Given this list of marker genes GMPPB, DIS3L2, PPP1R12A, TTC7A, MYH11, here is a description of the gene set: Ileal atresia An abnormal closure, or atresia of the tubular structure of the ileum. Human Gene Set: HP_ILEAL_ATRESIA studied in species Homo sapiens